The following is a description of a gene set: part of: SARS-CoV-2 Genome Replication and Transcription studied in species Homo sapiens Reactome Pathway: Transcription of SARS-CoV-2 sgRNAs This COVID‑19 pathway has been created by a combination of computational inference from SARS-CoV-1 data (https://reactome.org/documentation/inferred-events) and manual curation, as described in the summation for the overall SARS-CoV-2 infection pathway. Steps of SARS‑CoV‑2 transcription that have been studied directly include binding of the replication‑transcription complex (RTC) to the RNA template and the polymerase activity of nsp12, helicase activity of nsp13, capping activity of nsp16, and polyadenylation of SARS‑CoV‑2 transcripts. Remaining steps have been inferred from previous studies in SARS‑CoV‑1 and related coronaviruses.<br><br>SARS-CoV-1 encodes eight subgenomic RNAs, mRNA2 to mRNA9. mRNA1 corresponds to the genomic RNA. The 5' and 3' ends of subgenomic RNAs are identical, in accordance with the template switch model of coronavirus RNA transcription. Genomic positive strand RNA is first transcribed into negative sense (minus strand) subgenomic mRNAs by template switching. Negative sense mRNAs subsequently serve as templates for the synthesis of positive strand subgenomic mRNAs. As shown in murine hepatitis virus (MHV), which is closely related to SARS-CoV-1, negative-sense viral RNAs are present in much smaller amounts than positive-sense RNAs. Of the eight subgenomic mRNAs of SARS-CoV-1, mRNA2 encodes the S protein, mRNA3 is bicistronic and encodes proteins 3a and 3b, mRNA4 encodes the E protein, mRNA5 encodes the M protein, mRNA6 encodes protein 6, and bicistronic mRNA7, mRNA8 and mRNA9 encode proteins 7a and 7b (mRNA7), 8a and 8b (mRNA8), and 9a and N (mRNA9), respectively. The template switch model of coronavirus involves discontinuous transcription of subgenomic RNA, with the leader body joining occurring during the synthesis of minus strand RNAs. Each subgenomic RNA contains a leader transcription regulatory sequence (leader TRS) that is identical to the leader of the genome, appended via polymerase “jumping” during negative strand synthesis to the body transcription regulatory sequence (body TRS), a short, AU-rich motif of about 10 nucleotides found upstream of each ORF that is destined to become 5' proximal in one of the subgenomic mRNAs. The 3' and 5'UTRs may interact through RNA–RNA and/or RNA–protein plus protein–protein interactions to promote circularization of the coronavirus genome, placing the elongating minus strand in a favorable topology for leader-body joining. The host protein PABP was found to bind to the coronavirus 3' poly(A) tail and to interact with the host protein eIF-4G, a component of the three-subunit complex that binds to mRNA cap structures, which may promote the circularization of the coronavirus genome. Two viral proteins that bind to the coronavirus 5'UTR, the N protein and nsp1, may play a role in template switching. The poly(A) tail is necessary for the initiation of minus-strand RNA synthesis at the 3' end of genomic RNA. Elongation of nascent minus strand RNA continues until the first functional body TRS motif is encountered. A fixed proportion of replication-transcription complexes (RTCs) will either disregard the TRS motif and continue to elongate the nascent strand or stop synthesis of the nascent minus strand and relocate to the leader TRS, extending the minus strand by copying the 5' end of the genome. The completed minus-strand RNAs then serve as templates for positive strand mRNA synthesis., and this is the list of marker genes: N, rep, pp1a, SARS coronavirus, complete genome